The following is a description of a gene set: The process in which the anatomical structures of the tongue are generated and organized. The tongue is the movable, muscular organ on the floor of the mouth of most vertebrates, in man other mammals is the principal organ of taste, aids in the prehension of food, in swallowing, and in modifying the voice as in speech. Human Gene Set: GOBP_TONGUE_MORPHOGENESIS species: Homo sapiens, and this is the list of marker genes: TBX1, CYP26B1, CTNNB1, SIX4, HDAC2 (histone deacetylase 2), WDPCP, HDAC1, SIX1, INTU, HOXC13